The following is a description of a gene set: from publication Yagi T, Morimoto A, Eguchi M, Hibi S, Sako M, Ishii E, Mizutani S, Imashuku S, Ohki M, Ichikawa H (PMID 12738660) Most patients with acute myeloid leukemia (AML) enter complete remission (CR) after treatment with chemotherapy, but a large number of them experience relapse with resistant disease. To identify genes that are associated with their prognoses, we analyzed gene expression in 54 pediatric patients with AML using an oligonucleotide microarray that contained 12 566 probe sets. A supervised approach using the Student t test selected a prognostic set of genes, some of which are associated with the regulation of cell cycle and apoptosis. Most of these genes had not previously been reported to be associated with prognosis and were not correlated with morphologically classified French-American-British (FAB) subtypes or with karyotypes. These results indicate the existence of prognosis-associated genes that are independent of cell lineage and cytogenetic abnormalities, and they can provide therapeutic direction for individual risk-adapted therapy for pediatric AML patients. species: Homo sapiens Genes specifically expressed in samples from patients with pediatric AML (acute myeloid leukemia ) bearing t(8;21) translocation. Human Gene Set: YAGI_AML_WITH_T_8_21_TRANSLOCATION, and this is the list of marker genes: HLA-DRA, CD34, ABCC1, IL27RA, NUP210, BSG, ARID4A, NUP50, MKI67, CEACAM4, ESPL1, NFKB1, ITIH1, SSR1 (signal sequence receptor subunit 1), RALB, GLO1, NAP1L1, STIM1, IL2RG, DARS1, U2AF2, CDH4, NBAS, ANAPC10, ACTN2, BTN2A1, PSMD12, LAMA5, RCN1, EPB41L2, ITPR1, SLIT1, AP1B1, CCND1 (NCBI Gene Id 893), APOB, AKR1C3, NUMA1, ATP5MG, NTRK3, PTGDS, BTK, CAV1, NHERF1, NUDCD3, PRPF40A, ACSM3, UFD1, DGAT1, KMT2A, RAB4A, ZSCAN12 (NCBI Gene Id 9753), NFRKB, FKBP8, CCN3, GRM8, MPO, MED21, NCK1 (NCBI Gene Id 4690), HLA-DMB, DDT, ENSG00000235059, CSNK1G2, GNE, APP, CSTB, PLTP, ARID5B, BCR, FCGR2A, DLGAP2, AURKA, ZNNT1, ACKR3, LIMS1, ZNF117, CLDND1, S100A4, ARHGEF6, STARD8, VLDLR, IKBKE, GYPC, HLA-DPA1, ZNF85, HLA-DRB4, SLA, SCRN1, TSPAN3, TCEA2, TFAP4, SLC25A1, ACP2, TMBIM6, PNRC1, MACF1, CDKN2D, ECI1, QSOX1, CALR, SPART, SWAP70, VOPP1, NAA80, SACS, PBXIP1, ENOSF1, UGP2, NFIX, JUP, TIMELESS, GALR3, PI4KA, POU2F2, PEBP1, BCAM, SEPTIN11, STK10, TGOLN2, DUSP14, TMPRSS11D, CTAG1B, CITED1, ADCY3, ZC3H13, DDX39A, PRAME, PLP2, ZNF273, TGIF1, ZNF91, PSD3 (pleckstrin and Sec7 domain containing 3), ZNF254, CEACAM3, KDM4B (lysine demethylase 4B), HLA-DQB1, PRKCD (NCBI Gene Id 5580), CCN5, AREG, GPM6B, TPSAB1, TRAF3IP2, SYNGR1, MTMR9 (myotubularin related protein 9), BCL2L1, CYP2A13, AIF1, CD200, SASH3, PTPN12, ELANE, GPR6, CD96, TEK (NCBI Gene Id 7437), DDAH2, ELMO1, SOCS3, DPYSL2, FBLN5, PLAGL1, PIK3R1, HLA-DRB1, CCND3, SORD, ZC3H3, U2AF1, CDH19, SAP30, EPB41, SOCS5, PALM2AKAP2, IL1RAP, TTC28, CEP162, MRPL33, GNAS, CD68, LAPTM5, REL, VDR, GALNT1, TNFAIP2, CSK, ROBO1, CDR1, TRH, ALDH5A1, LGALS1, RUNX1T1, CAPG, SERPINE2, ZNF43, USP10, JAK1, CEP68, LEPROTL1, UNC13A, SIPA1L3, GLS (NCBI Gene Id 51679), GUCY1A2, POU4F1, COMT (catechol-O-methyltransferase), LIMK2, TSC22D4, RASA4, ITM2B, CD99, PXDN, ITGB4, ANKRD28, PLXND1, ZKSCAN4, MDK, TRIO, CLINT1, CFD (complement factor D), SMARCD1 (NCBI Gene Id 6602), RGS10, NT5C2, MARCHF6, ASGR2, DDR1, TGFBR1, ADRM1, ZNF160, GGCX, IL2, CDK9, NELFE, JAK3, GALNT2 (polypeptide N-acetylgalactosaminyltransferase 2), YBX1P5, LY75, ASF1A, CD58, NCALD, PALM, RFX5, FURIN, CDKN2C, UBA1, ZNF274, ACADSB, BLVRA, ADCY7, TSPAN7, CACNA2D2, KIT, RALBP1, CSF3R, TXNRD1, MPL, ANKLE2, NUP214, ERF, FBXO21, ADRA2C, NCF1, CTSF, VAMP5, PSMB3, RPS6KA1, CRLF3, ACOT13, MGMT, SCML1, CD226, PTGER2, GDE1, ETHE1, LCP1, CERS6, MED12, AGXT, STAT5B, RPP30, AGRN, VAT1, IL5RA, CCNG1, SH3GLB1, PLCG1, SMARCD2, OXSR1, TSR3, MPPE1, CTBP1, BRINP1, SCCPDH, CSRP2, GIP, COX8A, NBL1, EPCAM, TMF1, SEC62, ADK, LST1, HLA-DQA1, SFN, CIITA, FZD5, NUPR1, ATXN1, MAN1A1, GPS2, AGPAT2, TLE5, TFPI, UBA7, PROZ, SELPLG, HDAC1, TNFRSF21, GBA1LP, HEXA, HPGDS, AP3B1, PRTN3 (proteinase 3), CEP170, ATP5MC1, CAV2, ADNP2, TSPAN4, OSBP, APOOL, UTP20, SLC18A2, PTGIR, TSC2, TNFSF4, HLA-DPB1, CD74, MFAP4, AK4, MYRF (myelin regulatory factor), SST, MAGED2, CDH2, GUCY1A1, TNFRSF1A, SLC35D2, SHC1, MAGEB2, SORL1, FEV, SMG1, CD2AP, KDM3B, SLC1A4, BASP1, SIPA1L1, ABR, POLR2J, ELF4, CLSTN1, CXCR5, MEIS1, CUL4B, NDUFA2, FSCN1, ETV6, HLA-DMA, PTPRCAP, MS4A2, LYPD1, TRAT1, MAPKAPK3, GTPBP6, ORAI2, EXT2, TTC3, DGCR2, CDK14